Given this list of marker genes Ppp1r3g, Inpp5k, Epm2a, Adipoq, Epm2aip1, Gsk3a, Ppp1r3f, here is a description of the gene set: studied in species Mus musculus Mouse Gene Set: GOBP_REGULATION_OF_GLYCOGEN_STARCH_SYNTHASE_ACTIVITY Any process that modulates the frequency, rate or extent of glycogen (starch) synthase activity.